The following is a description of a gene set: species: Mus musculus The series of events required to receive a bitter taste stimulus, convert it to a molecular signal, and recognize and characterize the signal. This is a neurological process. Mouse Gene Set: GOBP_SENSORY_PERCEPTION_OF_BITTER_TASTE, and this is the list of marker genes: Tas2r143, Tas2r108, Tas2r122, Tas2r113, Tas2r139, Rtp4, Calhm1, Tas2r129, Tas2r130, Tas2r121, Tas2r116, Itpr3 (NCBI Gene Id 21779), Tas2r131, Tas2r117, Plcb2, Pip, Tas2r106, Reep2, Tas2r110, Tas2r118, Rtp2, Gnat2, Tas2r109, Tas2r119, Gnat3, Tas2r120, Car6, Azgp1, Rtp3, Pigr, Tas2r103, Tas2r115, Tas2r123, Tas2r124, Tas2r138, Tas2r126, Tas2r104, Tas2r136, Rgs21, Lpo, Tas2r137, Tas2r135, Tas2r134, Rtp1, Tas2r102, Tas2r125, Tas2r107, Tas2r105, Tas2r144, Tas2r140, Tas2r114, Gnat1